The following is a description of a gene set: RHOU GTPase cycle studied in species Homo sapiens Human Gene Set: REACTOME_RHOU_GTPASE_CYCLE, and this is the list of marker genes: STAM, MYO6, ITSN2, PTK2B, CDC42, TXNL1, SRGAP2, ARHGEF7, PARD6A, PAK4, CLTC, PAK1, HGS, NCK2, SPTAN1, PEAK1, PIK3R1, GIT1, DLG5, DEPDC1B, STAM2, ARHGAP31, ARHGAP30, EPHA2, PIK3R2, IQGAP1, PAK2, SPTBN1, GRB2, GIT2, DST, WDR6, VANGL1, PAK3, RHOU, SRC, USP9X, NCK1, ARHGEF6, WWP2